The following is a description of a gene set: Cluster 7: genes down-regulated early (within 24 h) after knockdown of OPN by RNAi in the NIH3T3 cells (fibroblasts) transformed by activated HRAS. Human Gene Set: TERAMOTO_OPN_TARGETS_CLUSTER_7 Activated forms of Ras family members are prevalent in many cancers where Ras mutants transduce signals essential for transformation, angiogenesis, invasion and metastasis. As a cancer progression model, we used NIH3T3 cells to explore the mechanism of Ras-induced tumorigenesis. Ras family mutants H-RasV12 and Rit79L strongly induced foci formation, while Rho family mutants RhoA-QL, Rac1-QL and Cdc42-QL were less effective. A comparison of downstream transcriptional targets of Ras and Rho family members using a 26 383 element cDNA microarray revealed that the osteopontin (OPN) gene exhibited the best correlation between magnitude of gene expression change and level of foci formation (r=0.96, P<0.001). In association with H-RasV12- and Rit79L-mediated transformation, foci secreted OPN protein and upregulated the OPN receptor CD44, suggesting the novel initiation of an aberrant OPN-CD44-Rac autocrine pathway. In support of this were the following observations. First, RGD-deficient OPN protein-binding activity was present in H-RasV12-transformed cells but not in control cells, and binding activity was inhibited by the CD44 blocking antibody. Second, foci formation, cell invasion and Rac activity were induced by H-RasV12 and inhibited by the CD44 blocking antibody. Third, foci formation by H-RasV12 was substantially reduced by a short interfering RNA (siRNA) specifically targeting OPN expression for knockdown. Fourth, H-RasV12-mediated transformation was not blocked by the GRGDS peptide, suggesting that OPN effects were not mediated by the integrins. Lastly, OPN knockdown affected the downstream expression of 160 '2nd tier' genes, and at least a subset of these genes appears to be involved in transformation. Indeed, four genes were selected for knockdown, each resulting in a disruption of foci formation and/or invasion. These results underscore the role of aberrant autocrine signaling and transcriptional networking during tumorigenesis. from publication Teramoto H, Castellone MD, Malek RL, Letwin N, Frank B, Gutkind JS, Lee NH (PMID 15516973) studied in species Mus musculus, and this is the list of marker genes: NFATC1, PPP1R15A, CTH, PHGDH, METTL2A, UGDH, NR1I3, MTHFD2, TFAP2A, WARS1, RAPGEF6, PDE3B, SLC4A10, S100A6, GPT2, SPP1, PSPH, RRBP1